The following is a description of a gene set: studied in species Homo sapiens Human Gene Set: HP_HITCHHIKER_THUMB Hitchhiker thumb With the hand relaxed and the thumb in the plane of the palm, the axis of the thumb forms an angle of at least 90 degrees with the long axis of the hand., and this is the list of marker genes: CNOT1, FLNB, SLC26A2, BPNT2, ALG9, CHSY1, MEGF8, CILK1